Given this list of marker genes MADCAM1, EMILIN1, SVEP1, ITGA9, ITGB1, here is a description of the gene set: species: Homo sapiens Human Gene Set: GOMF_INTEGRIN_BINDING_INVOLVED_IN_CELL_MATRIX_ADHESION Any integrin binding that occurs as part of the process of cell-matrix adhesion.